The following is a description of a gene set: studied in species Mus musculus Mouse Gene Set: GOBP_POSTSYNAPTIC_SIGNAL_TRANSDUCTION Signal transduction in which the initial step occurs in a postsynapse., and this is the list of marker genes: Chrna2, Chrnb1, Lypd1, Anxa7, Chrna6, Itpr1, Ly6a (NCBI Gene Id 17065), Chrnd, Ly6e, Gnai2, Rnf10, Ly6f, Sorbs2, Sorbs1, Hrh4, Chrnb4, Jak2, Ly6g6d, Ly6g6e, Abi1, Chrm1, Plcb1, Chrna7 (cholinergic receptor, nicotinic, alpha polypeptide 7), Large1, Psca, Stim1, Chrm5, Crtc1, Htt, Hrh3, Ly6g2, Chrna4, Nsmf, Ly6m, Ly6g6g, Cabp1, Chrnb2, Crkl, Prr7, Stat3 (NCBI Gene Id 68733), Chrna3, Chrnb3, Chrng, Ly6h, Ache (acetylcholinesterase), Chrne, Arrb2, Ly6i (NCBI Gene Id 57248), Nrg1, Nf1, Chrna1, Rgs10, Kpna1, Chrm4, Cdk5r1, Anks1b, Oprm1, Ly6c2, Ly6c1 (lymphocyte antigen 6 family member C1), Gnaq, Lynx1, Gna11, Chrna5, Chrm2, Camk4, Kpna2, Chrm3, Trpc1, Rela, Ly6g, Slurp2, Rgs8, Wnt3a, Prkcb (NCBI Gene Id 319718), Orai1